The following is a description of a gene set: Mouse Gene Set: GOMF_OMEGA_PEPTIDASE_ACTIVITY studied in species Mus musculus Catalysis of the cleavage of non-standard peptide bonds releasing substituted amino acids such as pyroglutamate or cleave isopeptide bonds, such as many deubiquitinating enzymes., and this is the list of marker genes: Pgpep1, Ggt6, Ggt1, Ggt7, Uchl1, Ggh, Apeh, Asrgl1, Ggt5, Trhde